Given this list of marker genes LDLR, ETV1, SOS1, FZD3, ZNF512B, EZH1, DNAJC27, PCDHA6, ANKFY1, CNOT6, OSTM1, TAFA1, NFAT5 (NCBI Gene Id 10725), FGD5, RAB8B, MAP3K14, SLC49A4, REV3L, CERCAM, FAT4, FOXK2, FRS2, ST6GALNAC6, EMSY, ZNF202, SPRED1, PCDHA11, TAGAP, KMT5B, TMEM100, RAPH1, GNB5, EPHA7, PURB, SOCS6, ARHGEF28, ZBTB8A, SERF1A, SALL1 (spalt like transcription factor 1), ARHGEF10, APCDD1 (NCBI Gene Id 85500), TFAM, NEDD4L, EGLN3, RAB11FIP5, PLCB1, ANKRD29, PCDHA4, MKNK2, ZNF236, UNC80, ANKH, PTPN3, RNASEH2B, F3, MAP3K9, STRIP2, URI1, SCAMP2, DPYSL2, GOSR1, NAPEPLD, ZC3H12C, AHNAK, HAS2, KLF12, EIF4A2, PAPOLA, ATG14, BHLHE41, SLC4A4, RAB5B, GNS, NABP1, MAPK4, FBXL3, SEMA4B (NCBI Gene Id 56962), CFL2, ZBTB9, WFS1, SERTAD2, PDGFRA, NEUROG1, CDKN1A, SRPK2, NDEL1, BNC2, NKIRAS1 (NCBI Gene Id 57083), KIAA0513, ERC1, TNFRSF21, REEP3 (NCBI Gene Id 221035), ZBTB41, SCN1A, CAPRIN2 (caprin family member 2), MTMR3, ANKRD52, CREB5, RSRP1, PPP1R3B, ANKIB1, MOSMO, MAPRE3, GLIS3, CD69, GUCY1A1, AKAP13, SUSD6, BICC1, TNKS2, PPP1R15B, ZFPM2, FNDC3B, U2SURP, CTSK, SSX2IP, ZNF704 (zinc finger protein 704), AKTIP (AKT interacting protein), SERP1, OSM, ST3GAL1, NIPA1, PCDHA7 (NCBI Gene Id 56141), PRR14L, ADARB1, CNOT6L, SORL1, REPS2, RBM12B, RAP2C, TRIM3, BBX, TXNIP, DYNC1LI2, PCDHA1, CROT (NCBI Gene Id 54677), HS3ST5, MTF1, RGMA, SLC4A8, USP6, PCDHA5, ENPP5, BNIP2, RAB11FIP1, PTPRD, ATXN1L, L3MBTL3, ZNF652, PCDHA10, CENPQ, ABI1, DPYSL5, SERF1B, AP2B1, THRA, RNF6, CORO2B (coronin 2B), USP3, PPP6C, APP, CHP2, MYNN, SMAD5, LIMA1, TAOK1, RBL2, PCDHA8, DUSP8, MCL1, GNPDA2, AGTPBP1, TET1, AGO1, CREB1, MIDN, KLHL2, DAB2, PAPOLB, ARAP2, IGSF10, TOPORS, TGFBR2, C2orf69, PDCD1LG2, IL6ST, FRMD6, USP31, NIBAN1, RHOC, FBXO31, OXR1, FJX1, SCN2B, KLHL15, SFMBT1, ABL2, HEG1 (heart development protein with EGF like domains 1), SCAMP5, TRDN, GXYLT1, PSD, LYST, NPLOC4, MEX3D, BTG3, AFG1L, REST, PRR16, ELK4, TGM2, ZDHHC1, BTBD7, MFAP3L (NCBI Gene Id 9848), SLC24A2, ZNF367, ACSL4, NFIB, XRN1, VASH2, LCOR, DNAL1, FOXJ3, FAM117B, TIAM1, ZFYVE26, YOD1, ARMC8, UXS1, DCUN1D1, RGL1, STK17B, OCRL, TMX3, C9orf40, CAMTA1, E2F5, SSH1, IRF9, PAK5, ROCK2, CAPN15, JAK1, WDFY3, ARHGEF18, FLT1, LAMA3 (laminin subunit alpha 3), DDX5, AGFG1, ISM2, CHD5, BAHD1, RAB22A, TMEM265, SMAD4, ATXN7L1, MCF2L, CMTR2, MASTL, KIF23, PRCP, RLIM, TRIM37, PCDHA2, ABHD5, PCDHAC2 (NCBI Gene Id 92387), ZBTB21, TBC1D9, SLC33A1, ZSCAN20 (NCBI Gene Id 96159), MAP10, CPEB3, PCDHAC1, CLOCK, CEP170, PEX5L (peroxisomal biogenesis factor 5 like), FBXL5, ZNF597, TRAPPC14, S1PR1, PSG3, DRD1, ZNF25, ZNFX1, MMP24, GABBR2, SMOC1, BCL11B, AKAP11, DENND10, C2CD2 (C2 calcium dependent domain containing 2), RBBP7, LRPAP1, KCNK10, FAM13C, RUFY2, ENTREP2, VSX1, ANKRD50, ZBTB7A, EGR2, MFN2, ZNF800 (zinc finger protein 800), USP24, CLIP4, PDLIM5, PCDHA12 (protocadherin alpha 12), EPHA4, ITPRIPL2, LRIG1, HSPA8, NRIP3, NPAS2, UBXN2A, LHX6, FCHO2, PDE3B, UNK, DNAJB9, UBE3C, KPNA2, BTN3A1, ZBTB20, ITGB8, FAM210A, MAP3K8, SPTY2D1, FGD4, PCDHA3, MED12L, PGBD5, ABCG4, PLXNA1, SLC40A1 (solute carrier family 40 member 1), OTUD4, ANKRD33B, PHC3, CYBRD1, E2F1, TAOK3, HLF, RGMB, RBL1 (RB transcriptional corepressor like 1), LRP8 (LDL receptor related protein 8), C14orf28, ANKRD17, USP32, RAPGEFL1, DNAJC16, KATNAL1, SESN3, PLAGL2, NANOS1, SLAIN2, RORC, HYCC2, RAB30 (NCBI Gene Id 27314), ITGA4, GPR137B, ATAD2, HAUS8, ARID4A, AGFG2, EREG, CNOT7, NCOA3, FBXO21 (NCBI Gene Id 23014), ZXDA, HIF1A, PXYLP1, UBE2Q2 (NCBI Gene Id 92912), IL1RAP, RUNX3, GPR63, TBC1D8B, MAP7, ORMDL3, GPR6, NAGK, SAMD8, LMO3, LASP1, TMEM127, LRCH1, NEUROG2, PTPN21, BMPR2, PTPN4, CMPK1, LDLRAP1, SRGAP1, DUSP2, FAT2, SH3PXD2A, CDC23, ADAM9, TBC1D20, CXCL6, P2RX4, ELK3, SQSTM1, EIF5A2, ULK1, CNOT4, SPOPL, NHLRC3, TSG101, TENM1, PHIP, TANC1, ZNF264, ZBTB4, SLITRK3, ABHD2, LIMK1, DDHD1, ZBTB33, KIF26B, SLC16A9, RRAS2 (RAS related 2), NTNG1 (netrin G1), ATP12A, IQSEC2, GRAMD1A, SACS, AAK1, KMT2B, BEST3, LPGAT1, SMOC2, HECTD2, RRAGD, FAM199X, BTBD10, PKD2, TNFAIP1, STXBP5, NIN, CMKLR1, ATG16L1, SNTB2, SGTB, RASL11B, PLXDC2, TRIP10, CHRM2, SSH2, PTHLH, SYTL4, OSR1, FNBP1L, MAP3K2, RETREG2, BCL2L11, TRIP11, MARCHF8, KCNJ10, CTSA, RAB12, ZBTB18, KLF11, SALL3, RAB10, SAMD12, BRWD1, TMBIM6, CC2D1A, ARHGAP12, SGMS1, EEIG1, PAG1, ARHGAP26, PFKP, WNK3, MAGI3, LRRC55, GAB1, ANO6, PCDHA13, PPP3R1, PPP1R21, CCNG2, CD274, SIKE1, KCNB1, MAPK8, GPR137C, USP28, ZNF280B, USP46, VANGL1, ABCA1, MYT1L, MINK1, RCCD1, RNF128, WEE1, GPATCH2, PBX3, CNRIP1 (NCBI Gene Id 25927), KLHL28, PIK3R1, PCDH15, GOLGA1, HTR2A, SLC45A4, FAM219B, SLC46A3, PXK, PTGDR, RASGRF2, TET3, TMEM138 (NCBI Gene Id 51524), DCBLD2, RETREG3, RRM2, TRPV6, FEM1C, SH3BP5, ATL3, TPRG1L, HPS5, ERAP1, TGFB1I1, LAPTM4A, FAM13A, UNKL, RPS6KA5, FBXO48 (F-box protein 48), SEMA7A, ATXN1, KAT2B, PTPDC1, BICD2, EPHA5, NTN4, WDR37, RPS6KA4, RB1CC1, PITPNA, MMP2, WDFY2 (WD repeat and FYVE domain containing 2), CCND1, RASD1, ANKRD13C, STAT3, KLF9, CEP97, PRR15, EPS15L1, SLC22A23, NUP35, SRCIN1 (NCBI Gene Id 80725), SLC16A6, CRY2, SLC17A7, VLDLR, PRRG1, SNX8, NR2C2, KMT2A, DOCK4, TRIM36, UEVLD, ZNF827, BRMS1L, NFIC, CALD1, ZDHHC9, LZIC, PRDM6, SNX16, STK11, KIF3B, TP73, ARHGEF3, OLFM3, EFCAB14, FASTK, NCKAP5, ARID4B, ZFYVE9, JPT1, ENTPD4, IRF1, TSPAN9, RORA, PFKFB3, MYO5B, FSD1L, ZNF148, ATG2B, NPAS3, MKRN1, NACC2, CCDC71L, PKD1 (NCBI Gene Id 5310), SAR1B, LYPD6, STYX, DERL2, RACGAP1, SUCO, ZHX2, TMEM64, TMEM167A, STK38, NPAT, FYCO1, SLMAP, NBEA, ARHGEF11, SEPTIN2, AMER2, CDC37L1, MFSD8, B3GALT2, PANX2, HBP1, PARD6B (NCBI Gene Id 84612), DENND5B, PLAG1, RPS6KA6, CRYBG3, TM2D2, ARHGAP1, NAA30, ZFAND4, MYLIP, PLEKHA3, SAMTOR, ZFP91, KIAA1191, SOX4, NR2C1, CSRNP3, MAPK1, CEP120, PGM2L1, RNH1, TMEM168, TNKS1BP1, here is a description of the gene set: from publication Chen Y, Wang X (PMID 31504780) species: Homo sapiens Genes predicted to be targets of miRBase v22 microRNA hsa-miR-106a-5p in miRDB v6.0 with MirTarget v4 prediction scores > 80 (high confidence targets). Human Gene Set: MIR106A_5P